Given this list of marker genes RPL23A, EVI2B, ABHD15, RPS12P28, MIR365B, MIR4725, ENSG00000265246, ABHD15-AS1, TMEM97, RNU6-298P, ARGFXP2, GTF2IP6, FLOT2, IFT20, UBL5P2, SSH2 (NCBI Gene Id 85464), SNORD42A, GPR160P2, SNORD63, MIR4733HG, LINC02978, PYY2, ENSG00000302531, GOSR1, RN7SL316P, RNU6-711P, MIR451B, NF1, RN7SL138P, SH3GL1P1, WDR45BP1, LGALS9, MIR3184, ALDOC, KRT17P3, SNORA70, PIPOX, SPACA3, RPS29P22 (NCBI Gene Id 100271384), ERVE-1, UTP6, OOSP1P2 (oocyte secreted protein 1 pseudogene 2), SARM1, POLDIP2, MIR4732, RPL31P58, ERAL1, OMG, RPL34P31 (NCBI Gene Id 731916), TMEM98, RNF135, SNORD42B, PHF12, RNU6-920P, UNC119, WSB1, SH3GL1P2, VN1R71P, RPL21P123, ENSG00000306328, LRRC37B, ENSG00000266313, SMURF2P1, RHOT1, LGALS9DP, MIR4523, DPRXP4, CDK5R1, CORO6, ATAD5, SDF2, CPDP1, TWF1P1, EFCAB5, MIR4522, SUZ12, NLK, MYO1D, C17orf75, MIR632, RNU6ATAC7P, ANKRD13B, TLCD1, SNORD4B, CRYBA1, KRT18P55, SLC13A2, RSKR, RNY4P13, TBC1D3P5, CRLF3, RN7SL45P, MYO18A, RPS16P8, MIR4733, BLTP2, FAM222B, TNFAIP1, ENSG00000239129, LINC01992, ENSG00000214708, MSANTD3P1, TAOK1, SLC6A4, NUFIP2, RHBDL3, RNU6-1134P, MIR4724, LRRC37BP1, SUZ12P1, NEK8, TMIGD1, PDLIM1P3, ENSG00000291063, VTN, MIR365BHG, PROCA1, SEBOX, LYRM9, SPAG5, RPL35AP35, MIR193A, TBC1D29P, ENSG00000265845, NSRP1, ALOX12P1, SLC46A1, TRAF4, AK4P1, SPAG5-AS1, MIR144, TEFM, MIR451A, ADAP2, FOXN1, SYPL1P2, SEZ6, RAB34, COPRS, PPY2P, ITM2BP1 (NCBI Gene Id 654367), SUPT6H, RNA5SP437, ENSG00000301334, PIGS, RNU4-34P, MIR4723, TMEM199, CPD, NOS2P1, H2BN1, MIR423, RPL9P30, RNU6-1034P, BLMH (NCBI Gene Id 642), RAB11FIP4, ZNF207, ALDOC-AS1, TUFMP1, GIT1, DHRS13, MYO1D-DT, TP53I13, H3P41, SNORD4A, KSR1, ENSG00000265222, RNU6-990P, RN7SL79P, NOS2, RNU6-1267P, PSMD11 (proteasome 26S subunit, non-ATPase 11), EVI2A (NCBI Gene Id 2123), RPS7P1, here is a description of the gene set: Human Gene Set: chr17q11 species: Homo sapiens